The following is a description of a gene set: species: Homo sapiens Genes up-regulated in comparison of myeloid dendritic cells (mDC) from TIV influenza vaccinee pre-vaccination versus those at day 7 post-vaccination. from publication Nakaya HI, Wrammert J, Lee EK, Racioppi L, Marie-Kunze S, Haining WN, Means AR, Kasturi SP, Khan N, Li GM, McCausland M, Kanchan V, Kokko KE, Li S, Elbein R, Mehta AK, Aderem A, Subbarao K, Ahmed R, Pulendran B (PMID 21743478) Systems vaccinology has emerged as an interdisciplinary field that combines systems wide measurements and network and predictive modeling applied to vaccinology. Here we used the systems vaccinology approach to study the molecular mechanisms underlying th Human Gene Set: GSE29618_PRE_VS_DAY7_POST_TIV_FLU_VACCINE_MDC_UP, and this is the list of marker genes: DLAT, RCN1, OSMR, NIF3L1 (NGG1 interacting factor 3 like 1), GSDME, UBTF, LY6G6E, SLC25A1 (NCBI Gene Id 6576), SEMA4D, COL8A1, DRD1 (dopamine receptor D1), PSORS1C2, ELAPOR1, INO80D, SLC38A6, IKZF2, PPOX, ATP2B4, DIO3 (iodothyronine deiodinase 3), CUL5, NEU3, ESM1, STBD1, TOGARAM1, TAF1C, GCHFR, MORC3, EXOC7, AOC3, MSMB, CENPM, CDA, STC2, SEMA7A, ASTN1, ZSCAN9, SLC16A1, APBB1, ADCYAP1, CLEC11A, AOX1, ZNF155, ZNF33B, IKZF1, MCOLN1, ZNF451, PPP2R5D, PMP2, GABRP, XAB2, FZD7, PDCD1, MCF2L2, ZNF423, ZNF614, RND3, SNAI1, SLC41A3, ZNF264, USP5, INKA2, CDK5R1, FBXL8, CAV3, TRIM58, WASF1, SLC24A2, TBC1D8B, UGCG, TMEM106C, COQ4, CSTF3, ARL4C, LLGL2, ZNF239, MAD2L1, TUBD1, TPP1, ZBTB32, ZNHIT2, RPRM, EEF1A1, CSF2, PRRC2B, TRAF3IP2, U2AF2, DTX2, FXR1, USP53, PHTF1, SKIL, SLC2A4RG, COG7, CCNJ, SNRNP35, ST20, SYNPO, SLC6A3, KCNJ13, PRR15L, AFF4, TXNL4B (NCBI Gene Id 54957), DTX4, KCNS3, ZMAT3, CA1 (NCBI Gene Id 759), NR3C1, COL3A1, LHX2, FCMR (NCBI Gene Id 9214), TMSB15A, SLAMF1, GABARAPL1, PTPN13, EDN2, TBK1, CENPF, CDR2L, DUSP13B, C19orf73, MIPEP (NCBI Gene Id 4285), CREB3L2, NKX2-5, NOP14, RCOR3, TCP11L1, IL33, KRR1, CD40, SIRT7, SYBU, KRTAP1-3, ZNF200, YBX1, CCR10, SPAG5, ATP6V0A1, EHD3, TMEM176B, JPH2, ADRB1, PPEF1, PPP1R17, CEP131, ITK, APOC2, CDC42, DYNC2I1, GAL3ST4, IP6K1, CDC6, AMMECR1, ZNF37BP, ZNF3, IGHV5-78, RNF141, CASK (NCBI Gene Id 8573), EPB41L4A, RNF146 (ring finger protein 146), REPS2, PCDHA9, ARPIN, THSD7A, SMAD6, PLLP, TRGV5, WDR48, NRIP1, FGF3, BCL2, TFAP4, ADAMTS5, TAOK2, GABPA, SPICE1, HIGD1B, PKIA, PCDHB6, GPR162, SSR1, GNGT1, FSCN3, SLC3A1, YRDC, ENTPD4, YLPM1, CDKN2B, TNFRSF9, ADNP2, TNFSF9, ATRNL1, STK17A, TSFM, OPRM1, SLITRK5, C2CD3, KRT84, MRTFB, CCDC68